Given this list of marker genes TBX22, MYH3, PIK3R1, KCNJ6, KDM6A, PIK3CA, SEMA3E, CASP2, SPECC1L, RUNX2, TWIST2, TFAP2A, KMT2D, EZH2, NALCN, SMARCA2, CTU2, CHD7, PIEZO2, here is a description of the gene set: Human Gene Set: HP_DIMPLE_CHIN Dimple chin studied in species Homo sapiens A persistent midline depression of the skin over the fat pad of the chin.